Given this list of marker genes PCSK5 (NCBI Gene Id 96284), FURIN, ADAM17, CASP1, CMA1, here is a description of the gene set: Human Gene Set: GOBP_CYTOKINE_PRECURSOR_PROCESSING studied in species Homo sapiens The cleavage of a peptide bond in a precursor form of a cytokine, resulting in the mature (active) form of the cytokine.